The following is a description of a gene set: Human Gene Set: APPEL_IMATINIB_RESPONSE from publication Appel S, Rupf A, Weck MM, Schoor O, Brümmendorf TH, Weinschenk T, Grünebach F, Brossart P (PMID 15756019) Genes up-regulated by imatinib during dendritic cell differentiation. Dendritic cells are the most powerful antigen-presenting cells playing a decisive role for the initiation and maintenance of primary immune responses. However, signaling pathways involved in the differentiation of these cells have not been fully determined. Imatinib is a novel tyrosine kinase inhibitor effective against Abl kinases, c-Kit, and platelet-derived growth factor receptor. Using this compound, we show that human monocyte-derived dendritic cells generated in the presence of therapeutic concentrations of imatinib show a reduced expression of CD1a, MHC class I and II, and costimulatory molecules as well as decreased secretion of chemokines and cytokines resulting in an impaired capacity of dendritic cells to elicit primary T-cell responses. Using Western blot analyses, we found that these effects are mediated by inhibition of phosphatidylinositol 3-kinase/Akt pathways and a pronounced down-regulation of nuclear localized protein levels of nuclear factor-kappaB family members. Importantly, using blocking antibodies and tyrosine kinase inhibitors, we show that the inhibitory effects of imatinib on dendritic cell differentiation are not mediated via platelet-derived growth factor receptor and c-Kit. Taken together, our study reveals that imatinib inhibits dendritic cell differentiation and function via Akt and nuclear factor-kappaB signal transduction. Importantly, we show that imatinib can inhibit the function of normal, nonmalignant cells that may result in immunosuppression of these patients. studied in species Homo sapiens, and this is the list of marker genes: FUCA1, NEU1, CTSA, CTSB, CTSH, ENG, APOE, CD68, MSR1, LAMP1, HEXA, PPARG, HEXB, CD163, ACP5, PLD1, GNS, GM2A, CTSZ, CD300A, LAMP2, ASAH1, GBA1, C5AR1 (complement C5a receptor 1), GUSB, CTSD, CTSL, PLSCR1, OSBPL3, RARRES1, APOD (NCBI Gene Id 347), LILRB3, APOC1